Given this list of marker genes BUB1B, CUL7, UBE2S, ANAPC13, MAD2L2, ANAPC10, CDC23, CDC27, ANAPC11, ANAPC15, ANAPC16, CDC20B, ANAPC5, FZR1, CDC20, CDC16, UBE2C, CDC26, ANAPC1, ANAPC4, ANAPC7, ANAPC2, here is a description of the gene set: Human Gene Set: GOCC_ANAPHASE_PROMOTING_COMPLEX A ubiquitin ligase complex that degrades mitotic cyclins and anaphase inhibitory protein, thereby triggering sister chromatid separation and exit from mitosis. Substrate recognition by APC occurs through degradation signals, the most common of which is termed the Dbox degradation motif, originally discovered in cyclin B. studied in species Homo sapiens